Given this list of marker genes CREBBP, NUP37, HLA-C, TAB2 (TGF-beta activated kinase 1 (MAP3K7) binding protein 2), UBA52, NUP155, HLA-A, RIPK2, RANBP2, TPR, rep, SEC23A, POM121, RNF135, IFNA7, IFNB1, UBB, N, NUP133, SEH1L, IFNA16, NUP50, STAT2, IRF7, IRAK2, MAP3K7, HLA-F, NUP160, ISG15, TLR7, TKFC, UBC, IFNA21, PTPN6, TLR2, IFNA10, BECN1, G3BP2 (G3BP stress granule assembly factor 2), KPNA2, HSP90AA1, TAB1, NOD2, JAK1, SEC24B, NUP188, POM121C, IKBKE, IFNA6, IL17A, NUP107, MASP2, SIKE1, PIK3R4, NOD1, NLRP3, TRAF3, pp1a, 8, MAVS, TYK2, NUP54, MBL2, NUP85, IL17RC, NUP153, HSP90AB1, STAT1, SAR1B, CNBP, IFNAR1, IFNA2, NUP43, IFNAR2, NUP93 (NCBI Gene Id 9688), IL17F, IFIH1, TRAF6, SEC24D, STING1, HLA-G, 6, SEC24A, ATG14 (autophagy related 14), 7a, NUP98, M, RAE1, NDC1, HLA-H, SFTPD, MASP1, UBE2V1, UBE2N, NUP205, TAB3, RPS27A, TBK1, LARP1 (La ribonucleoprotein 1, translational regulator), IRF3, IKBKB, IL17RA, IFNA14, G3BP1, NUP210, CHUK, IFNA1, TRIM25, TRIM4, TLR1, RIGI, HLA-E, SEC13, IFNA17, TOMM70, SARS coronavirus, complete genome, PIK3C3, IRAK1, NUP214, IFNA8, B2M, NLRP12, IFNA4, NUP42, SEC24C, IFNA5, HLA-B, NUP35, AAAS, NUP58, IKBKG, NUP62, TLR8, 3a, 9b, E, S, NUP88, PTPN11, here is a description of the gene set: Reactome Pathway: SARS-CoV-2 activates/modulates innate and adaptive immune responses part of: SARS-CoV-2-host interactions Coronaviruses (CoVs) are positive-sense RNA viruses that replicate in the interior of double membrane vesicles (DMV) in the cytoplasm of infected cells (Stertz S et al. 2007; Knoops K et al. 2008; V'kovski P et al. 2021). The viral replication and transcription are facilitated by virus-encoded non-structural proteins (SARS-CoV-2 nsp1–nsp16) that assemble to form a DMV-bound replication-transcription complex (RTC) (V'kovski P et al. 2021). The replication strategy of CoVs can generate both single-stranded RNA (ssRNA) and double-stranded RNA (dsRNA) species, that may act as pathogen-associated molecular patterns (PAMPs) recognized by pattern recognition receptor (PRR) such as toll-like receptor 7 (TLR7) and TLR8, antiviral innate immune response receptor RIG-I (also known as DEAD box protein 58, DDX58) and interferon-induced helicase C domain-containing protein 1 (IFIH1, also known as MDA5) (Salvi V et al. 2021; Campbell GR et al. 2021; Rebendenne A et al. 2021). The activated PRRs trigger signaling pathways to produce type I and type III interferons IFNs and proinflammatory mediators that perform antiviral functions. First, endosomal recognition of viral ssRNA occurs by means of TLR7 and TLR8, which detect GU-rich ssRNA sequences (Salvi V et al. 2021; Campbell GR et al. 2021). Second, SARS-CoV-2 dsRNA replication intermediates can be recognized by cytoplasmic receptors DDX58 and IFIH1 which bind to mitochondrial antiviral-signaling protein (MAVS, IPS-1) to induce the IFN-mediated antiviral response (Rebendenne A et al. 2021; Yin X et al. 2021). In addition, SARS-CoV-2 E can be sensed by TLR2 (Zheng M et al. 2021). Further, cellular nucleic acid-binding protein (CNBP) and La-related protein 1 (LARP1) can directly bind SARS-CoV-2 gRNA to repress SARS-CoV-2 replication (Schmidt N et al. 2021). This module also describes several strategies developed by SARS-CoV-2 to evade or alter host immunity, including escaping innate immune sensors, inhibiting IFN production and signaling, and evading antiviral function of IFN stimulated gene (ISG) products. For example, SARS-CoV-2 encodes nsp14 and nsp16 which possess guanine-N7-methyltransferase activity and 2’-O-methyl-transferase activity respectively (Ogando NS et al. 2020; Krafcikova P et al. 2020; Viswanatha T et al. 2020; Lin S et al. 2021; Yan L et al. 2021). In human coronaviruses nsp14 generates 5' cap-0 viral RNA (m7GpppN, guanine N7-methylated) and nsp16 further methylates cap-0 viral RNA. These viral RNA modifications mimic the 5'-cap structure of host mRNAs allowing the virus to efficiently evade recognition by cytosolic DDX58 and IFIH1 (Chen Y et al. 2009, 2011; Daffis S et al. 2010, shown for CoVs such as SARS-CoV-1 and MERS-CoV). Structural studies and computational analysis suggest that properties and biological functions of SARS-CoV-2 nsp14 and nsp16 could be very similar to these of SARS-CoV-1 (Rosas-Lemus M et al. 2020; Lin S et al. 2020; Viswanathan T et al. 2020; Krafcikova P et al. 2020; Jiang Y et al. 2020; Wilamowski M et al. 2021). Further, the uridylate‐specific endoribonuclease (EndoU) activity of SARS-CoV-2 nsp15 degrades viral RNA to hide it from innate immune sensors (Frazier MN et al. 2021). Moreover, SARS-CoV-2 encodes several proteins that directly bind to host targets associated with SARS‑CoV‑2 infection and cytokine production (Shin D et al. 2020; Viswanathan T et al. 2020; Xia H et al. 2020; Matsuyama T et al. 2020; Yuen CK et al. 2020; reviewed by Park A & Iwasaki A 2020). For example, as a deubiquitinating and deISGylating enzyme, viral nsp3 binds to and removes ISG15 from signaling proteins such as IRF3 and IFIH1 thereby modulating the formation of signaling complexes and the activation of IRF3/7 and NF-kappaB (Liu CQ et al. 2021). Binding of SARS-CoV-2 nsp6, nsp13 or membrane (M) protein to cytosolic TBK1 prevents IRF3/7 activation and inhibits IFN production downstream of DDX58, IFIH1, MAVS and STING signaling pathways (Xia H et al. 2020; Sui L et al. 2021). Next, M protein targets MAVS to prevent the formation of the MAVS signalosome complex and thereby inhibits downstream signaling pathways of DDX58 and IFIH1 (Fu YZ et al. 2021). Binding of SARS-CoV-2 nucleocapsid (N) protein to E3 ubiquitin ligase TRIM25 inhibits TRIM25-mediated DDX58 ubiquitination and the DDX58 signaling pathway (Gori SG et al. 2021). N interacts with NLRP3 to promote the assembly and activation of the NLRP3 inflammasome (Pan P et al. 2021). The interaction between viral N and MASP2 promotes MASP2-mediated cleavage of C4 (Ali YM et al. 2021) and C2 (Kang S et al. 2021) leading to the hyperactivation of the complement system. Besides, viral N promotes NF-kappaB activation by targeting signaling complexes of TAK1 and IKK (Wu Y et al. 2021). The ion channel activities of accessory protein ORF3a or 3a (open reading frame 3a) and SARS‑CoV‑2 envelope (E) protein contribute to activation of the NLRP3 inflammasome leading to highly inflammatory pyroptotic cell death (based on findings for SARS-CoV-1, Siu KL et al. 2019). SARS-CoV-2 nsp5 protease (3CLpro) cleaves TAB1, a component of the TAK1 complex, thus inhibiting NF-kappaB activation (Moustaqil M et al.2021). 3CLpro targets NLRP12 which modulates the expression of inflammatory cytokines through the regulation of the NFkappaB and MAPK pathways (Moustaqil M et al. 2021). SARS-CoV-2 6 (ORF6) interacts with importin KPNA2 and components of the nuclear pore complex, NUP98 and RAE1, to block nuclear translocation of IRF3, STAT1 and STAT2 (Xia H et al. 2020; Miorin L et al. 2020). SARS-CoV-2 9b (ORF9b) inhibits the MAVS-mediated production of type I IFNs by targeting TOMM70 on the mitochondria (Jiang HW et al. 2020). Binding of mitochondrial viral 9 to IKBKG prevents MAVS-dependent NF-kappaB activation (Wu J et al. 2021). Although the evasion mechanisms are mainly conserved between SARS-CoV-1 and SARS-CoV-2 (Gordon DE et al. 2020), studies identified SARS-CoV-2-specific modulations of host immune response that may contribute to pathophysiological determinants of COVID-19 (Gordon DE et al. 2020; Schiller HB et al. 2021). For example, SARS-CoV-2 8 (ORF8) regulates the expression of class I MHC on the surface of the infected cells through an autophagy-dependent lysosomal degradation of class I MHC (Zhang Y et al. 2021). At the plasma membrane, binding of secreted viral 8 to IL17RA activates IL17 signaling pathway leading to an increased secretion of cytokines/chemokines thus contributing to cytokine storm during SARS-CoV-2 infection (Lin X et al. 2021). Furthermore, SARS-CoV-2-host interactome and proteomics studies identified various human proteins that are targeted by SARS-CoV-2 proteins (Gordon DE et al. 2020a, b; Bojkova D et al. 2020; Stukalov A et al. 2021; Li J et al. 2021; Messina F et al. 2021). studied in species Homo sapiens